Given this list of marker genes UBE2C, DNM3OS, WWTR1, RPL23AP59, TTC23 (NCBI Gene Id 64927), ARID5B, ANTXR2, ADCY9, ANKS6, RPL32P9, FCRLA (Fc receptor like A), DLG5, WARS1, RNU6-494P, SULF1, NT5C2, PPIAP80, ENSG00000235979, LINC01625 (NCBI Gene Id 651891), PM20D2, RNU6-565P, NOSIP, LINC00689, RNU6-554P, ZEB2, TMPRSS7, MIR199A2, STX18, WDR7, ZNF385D-AS2, KDM2B, KDM2B-DT, POR, DPYD-AS2, ARPP21, KIAA0319, DNAJB4, FAP, CREB1, RPSAP52, EEF1A1P25, SH3GLB1, CSDE1, RN7SL738P, SUCNR1, MEOX1, CUL3, AFP, PDE4D, SYTL2, ATP13A1, KCNH7-AS1, RPL15P22, LIMCH1, FENDRR, DHX30, VEZT, GP6, VPS51P1, ZNF521, DNAH5, RNU6-369P, PCARE, ANKRD13A, SIM1-AS1, STRC, KATNIP, COLQ, CTBP2, ABAT (NCBI Gene Id 731754), AGO2, LINC01870, STOX2, LINC02861, RPL7AP26, NELL1, JMJD1C, ELF1, RPL23P8, TLE6, RN7SL89P (RNA, 7SL, cytoplasmic 89, pseudogene), ENSG00000212551, STATH, LINC01082, HDAC9-AS1, POMT2, SLC19A3, P2RX6, MUSTN1, MALSU1, CEP350, LAMC1, ASPA, LINC01730, ALOX15, KANK4, RMND5A, MAP3K7, SAMD13, RNU6-922P, POPDC3, BAALC, SUN1, MCC, PIPOX, MDS2, SDC3, ENSG00000227496, ENSG00000227157, HMGA2 (NCBI Gene Id 8091), DMRTA2, LINC01111 (NCBI Gene Id 101926978), RNU6-353P, SLC7A7, PRKAG2-AS2, LIMA1, COL25A1, LINC02139, RAD51B, ASS1, RPS4XP14, WSCD1, ERICH1, ENSG00000248964, ZBTB20-AS5, here is a description of the gene set: studied in species Homo sapiens Human Gene Set: PRDM5_TARGET_GENES from publication Yevshin I, Sharipov R, Kolmykov S, Kondrakhin Y, Kolpakov F (PMID 30445619) Genes containing one or more binding sites for (PRDM5) in their promoter regions (TSS -1000,+100 bp) as identified by GTRD version 20.06 ChIP-seq harmonization.